The following is a description of a gene set: studied in species Homo sapiens Genes up-regulated in dendritic cell wildtype LPS and anti-CD40 stimulated versus dendritic cell NIK NFkB2-KO LPS and anti-CD40 stimulated. from publication Lind EF, Ahonen CL, Wasiuk A, Kosaka Y, Becher B, Bennett KA, Noelle RJ (PMID 18566401) Human Gene Set: GSE7219_WT_VS_NIK_NFKB2_KO_LPS_AND_ANTI_CD40_STIM_DC_UP This study aims at identifying genes that are NIK/NF-kappaB2 responsive in murine dendritic cells matured in vivo., and this is the list of marker genes: SEMA4F, ITGB3 (integrin subunit beta 3), CDC25B, SPINK4, SPC24, RNASEH2C, TENT4A, FABP5, HDAC6, SYNC, KRT86, IL15, NCOA1, TLE1, SPRY2, GDF15, RHOBTB1, UBE2C, CCDC47, TMEM176A (NCBI Gene Id 96710), SHCBP1, IFRD1, STAT3, CCNB2, SSBP3 (NCBI Gene Id 55126), SFXN1, BIRC5, PTPDC1, SAMD4A, STMN1, FUT8 (fucosyltransferase 8), EDNRA, NSMCE1, BMPR1A, RALGAPA2, BORA, DNAH2, CRTAM, SLC6A12, CA2, USP46, ZFP36L2, DDIT4, SUCNR1, CCR3, BPIFC, FOXRED2, BANK1, IFITM3, MCU (mitochondrial calcium uniporter), NTN4, MFHAS1, TEX9, UBE2J2, HMGB2, SLC6A13, TOB1, TIMP3, MLPH, OXSR1, MKI67, C4orf46, ST6GALNAC2, IQGAP2, LRRC75A, F13A1, NRN1, HSPA4, BACE2, FBXO9, AQP8, PAQR4, CDK1, ABCB10, CENPW, HBE1, TOLLIP, PLEK, NCAPG2, TAMM41, TWIST2 (twist family bHLH transcription factor 2), RIOK1, HMMR, TUBA8, GDPD1, ACAA2, NEB, TPX2, RAPSN, ANP32E (NCBI Gene Id 81611), RAB13, TMEM176B, SSBP2, TSPAN8, SLA, SERTAD3, HDDC2, FBXO7, NPL, CRP, TMCO3, SMOX, ARHGAP28, IDI1, H1-0, SVIL, KIFAP3, ANLN, CD300C, MGST2, FADS1 (fatty acid desaturase 1), IL7R, HEY2, HMGN5, CDH2, ATP1B2, KLHL23 (NCBI Gene Id 151230), MED12L, DUSP4, BUB1, C3orf52, RORA, PHETA2, OTOP1 (otopetrin 1), NRGN, CENPI, ESCO2, GORAB, TGM2, DOCK1, DUT, TBC1D30, CDCA3, TOX, GMPR (guanosine monophosphate reductase), TMEM158, CCL7, DEPTOR, SLC4A4, TMEM107, TK1, ST3GAL5, MBOAT7, LPP, SLC39A8, TMEM273, RRM2, PADI2, HSDL2, SMARCA1, TRPC6, CAMK1D, HMGB3, MACROD2, GRIA3, UCK1, NLRP3, ZRSR2, DHFR, FADS2, SAMD5, DLG3, SCARA5, NOTCH3, LRATD1, SNAI2, SVIP, CMTM6, PGR, EMD, APOE, PPEF2, CLEC6A, SERPINB2, NRIP3, TFDP2, CNTNAP2, CCN5, SRSF6, FANCL, KLF2, VCAN, GALNT3, SGF29, H1-4, CKAP4, TTC21B, LRP6, CYP4A22, RABEP1, ADIPOR2, DYRK3, CHML, ITIH5, NGFR, EPOR, GOLM2, KCNQ1, HBEGF, GCSAM